The following is a description of a gene set: Genes up-regulated in Harderian gland tissue upon knockout of AOX4. from publication Terao M, Kurosaki M, Barzago MM, Fratelli M, Bagnati R, Bastone A, Giudice C, Scanziani E, Mancuso A, Tiveron C, Garattini E (PMID 18981221) studied in species Mus musculus The mouse aldehyde oxidase AOH2 (aldehyde oxidase homolog 2) is a molybdoflavoenzyme. Harderian glands are the richest source of AOH2, although the protein is detectable also in sebaceous glands, epidermis, and other keratinized epithelia. The levels of AOH2 in the Harderian gland and skin are controlled by genetic background, being maximal in CD1 and C57BL/6 and minimal in DBA/2, CBA, and 129/Sv strains. Testosterone is a negative regulator of AOH2 in Harderian glands. Purified AOH2 oxidizes retinaldehyde into retinoic acid, while it is devoid of pyridoxal-oxidizing activity. Aoh2(-/-) mice, the first aldehyde oxidase knockout animals ever generated, are viable and fertile. The data obtained for this knockout model indicate a significant role of AOH2 in the local synthesis and biodisposition of endogenous retinoids in the Harderian gland and skin. The Harderian gland's transcriptome of knockout mice demonstrates overall downregulation of direct retinoid-dependent genes as well as perturbations in pathways controlling lipid homeostasis and cellular secretion, particularly in sexually immature animals. The skin of knockout mice is characterized by thickening of the epidermis in basal conditions and after UV light exposure. This has correlates in the corresponding transcriptome, which shows enrichment and overall upregulation of genes involved in hypertrophic responses. Human Gene Set: TERAO_AOX4_TARGETS_HG_UP, and this is the list of marker genes: TMEM127, TRAPPC10, TTC7A, SNX27, NAA60, PEA15, MAP1LC3A, RNF185, PAM, MIA2, CEBPA, ACSL6, UBE2V1, GNS, SBF2, PEX5, KIAA0930, GNA12, NSF, RAF1, CYTH1, TXNDC5, MFSD9, INTS4, RNF4, CYP2B6, SGPL1, AP1S3